Given this list of marker genes Stom, Gyg1, Nr1h3, Fabp4, Cebpa, Hsd11b1, Pck1, Cp, Mmd, Cd36, Lipe, Pparg, Enpp2, Cidea, Retn, Pnpla2, Ffar2, Hp, Cidec, Adipoq, Acsl1, here is a description of the gene set: Genes up-regulated during adipogenesis of 3T3-L1 cells (fibroblast). species: Mus musculus from publication Steger DJ, Lefterova MI, Ying L, Stonestrom AJ, Schupp M, Zhuo D, Vakoc AL, Kim JE, Chen J, Lazar MA, Blobel GA, Vakoc CR (PMID 18285465) The histone H3 lysine 79 methyltransferase DOT1L/KMT4 can promote an oncogenic pattern of gene expression through binding with several MLL fusion partners found in acute leukemia. However, the normal function of DOT1L in mammalian gene regulation is poorly understood. Here we report that DOT1L recruitment is ubiquitously coupled with active transcription in diverse mammalian cell types. DOT1L preferentially occupies the proximal transcribed region of active genes, correlating with enrichment of H3K79 di- and trimethylation. Furthermore, Dot1l mutant fibroblasts lacked H3K79 di- and trimethylation at all sites examined, indicating that DOT1L is the sole enzyme responsible for these marks. Importantly, we identified chromatin immunoprecipitation (ChIP) assay conditions necessary for reliable H3K79 methylation detection. ChIP-chip tiling arrays revealed that levels of all degrees of genic H3K79 methylation correlate with mRNA abundance and dynamically respond to changes in gene activity. Conversion of H3K79 monomethylation into di- and trimethylation correlated with the transition from low- to high-level gene transcription. We also observed enrichment of H3K79 monomethylation at intergenic regions occupied by DNA-binding transcriptional activators. Our findings highlight several similarities between the patterning of H3K4 methylation and that of H3K79 methylation in mammalian chromatin, suggesting a widespread mechanism for parallel or sequential recruitment of DOT1L and MLL to genes in their normal on state. Mouse Gene Set: STEGER_ADIPOGENESIS_UP